Given this list of marker genes CSF1R, POU2F2, ABI3, LILRB1, IMPDH1, MEG3, ARAP1 (ArfGAP with RhoGAP domain, ankyrin repeat and PH domain 1), FMNL2, IFITM3, PTP4A3, CCNG2, KLF3, PPP1R17, PKN1, SCIMP, RAB10, NEURL1, ADGRE2, ZG16B, ISG15, RNF149, C5AR1, C1QB (complement C1q B chain), WAS, CALM2, SPN, SERPINA1, DRAP1, APH1B, PHTF2, MYD88, CLCF1, LINC00877, ITGAX, KIAA0513, PECAM1, KNDC1, SLC7A7, ST3GAL5, PTPRN2-AS1, S100A11, FAM110A, CYP4F22, CAPZB, MRAS, CAPZA2, SIGLEC10, CUX1, AMPD2, LRRC25, MMP24OS, OAZ2, VAMP5, NAPRT, CACUL1, NAP1L1, LINC02345, CHCHD10, PPM1F, GBP2, PSME2, TCF7L2, LFNG, LYN, PTPN6, PSAP, LY6E (NCBI Gene Id 7999), UQCRB, RARA, GPR137B, RNF144B, SCGB3A1, INSIG1, CKB, MTPN, LINC02432, ADGRE1, GPR20, PAPSS2, SNX18, SYNGR2, SIDT2, LYPD2, SMAP2, ZNF703 (zinc finger protein 703), FMNL1, GNB2, MYL6, KDM1B, MYO1G, C11orf21, RGS19 (regulator of G protein signaling 19), SH3BGRL, NAGK, NFKBIZ, VASP, SPI1, TMSB4X, LST1, CALHM2, RNH1, DENND10, PGK1, PPCDC, CHST15, VMO1, MSR1, CDH23, ACAA1, CYTIP (cytohesin 1 interacting protein), HCK, CD300LF, GRK2, OAS1, CDKN1C (NCBI Gene Id 702), C5AR2, SEC14L1, PRELID1, PILRA, TENT5A, CD68, C3AR1, JPT1, ARRB2, RRAS, CAMK1, CASP5, PDK4, ATOSB, SMPDL3A, FIBCD1, TPPP3, BATF3, TBXAS1, ITLN1, HK3, RIN3, NAAA, PELATON, MTSS1 (MTSS I-BAR domain containing 1), COTL1 (coactosin like F-actin binding protein 1), LILRA2, SELPLG, C19orf38, TUBA1A, FGR, CPPED1, BID (NCBI Gene Id 637, BH3 interacting domain death agonist), LINC01503, ARPC5, TNFRSF8, GRK3, TBC1D8, PDLIM5, UTRN, THEMIS2, ARPC1B, C1QA, SAT1 (spermidine/spermine N1-acetyltransferase 1), LILRA5 (leukocyte immunoglobulin like receptor A5), FCER1G, SLC2A6, TNFSF10, CXCL16, TNFRSF1B, CHST7, PLXNB2, UNC119, WARS1, SFTPD, MAPKAPK3, DEDD2, LILRB2, ARPC3, ZMYND15, FCGR3A, FGD2, NR4A1, CTSL, PIK3AP1, CEACAM3, CALHM6, SLC66A3, ARRB1, CMTM6, YPEL2, SLC31A2, HSBP1, SYT17, DPEP2, GPBAR1, PTGES, PCGF5, RNASET2, SLC25A6, RHOG, CD300C, MS4A7, GNG5, HES4, RALB, HIGD2A, AIF1, RHOC, FTH1, LGALS9, VSIR, LILRA1, PPM1N, LRRFIP1, DOCK5, HOTAIRM1, GCH1, TCIRG1, P2RX1, FKBP1A, ADAP2, CARD9, RABGAP1L, TIMP1, LYNX1, LINC02185, MCOLN1, CSTB, NUDT16, RNF13, here is a description of the gene set: from publication Hay SB, Ferchen K, Chetal K, Grimes HL, Salomonis N (PMID 30243574) Human Gene Set: HAY_BONE_MARROW_MONOCYTE species: Homo sapiens